The following is a description of a gene set: studied in species Mus musculus Mouse Gene Set: GOBP_PTERIDINE_CONTAINING_COMPOUND_CATABOLIC_PROCESS The chemical reactions and pathways resulting in the breakdown of any compound containing pteridine (pyrazino(2,3-dipyrimidine)), e.g. pteroic acid, xanthopterin and folic acid., and this is the list of marker genes: Aldh1l1, Aldh1l2, Mthfsl, Aasdhppt, Pm20d2